Given this list of marker genes PDGFRB, FLT4, NSD1, ARHGAP26, TLX3, LIFR, NPM1, ACSL6, APC, RANBP17, here is a description of the gene set: DNA copy number amplifications activate oncogenes and are hallmarks of nearly all advanced tumors. Amplified genes represent attractive targets for therapy, diagnostics and prognostics. To investigate DNA amplifications in different neoplasms, we performed a bibliomics survey using 838 published chromosomal comparative genomic hybridization studies and collected amplification data at chromosome band resolution from more than 4500 cases. Amplification profiles were determined for 73 distinct neoplasms. Neoplasms were clustered according to the amplification profiles, and frequently amplified chromosomal loci (amplification hot spots) were identified using computational modeling. To investigate the site specificity and mechanisms of gene amplifications, colocalization of amplification hot spots, cancer genes, fragile sites, virus integration sites and gene size cohorts were tested in a statistical framework. Amplification-based clustering demonstrated that cancers with similar etiology, cell-of-origin or topographical location have a tendency to obtain convergent amplification profiles. The identified amplification hot spots were colocalized with the known fragile sites, cancer genes and virus integration sites, but global statistical significance could not be ascertained. Large genes were significantly overrepresented on the fragile sites and the reported amplification hot spots. These findings indicate that amplifications are selected in the cancer tissue environment according to the qualitative traits and localization of cancer genes. from publication Myllykangas S, Himberg J, Böhling T, Nagy B, Hollmén J, Knuutila S (PMID 16751803) species: Homo sapiens Human Gene Set: MYLLYKANGAS_AMPLIFICATION_HOT_SPOT_27 Amplification hot spot 27: colocalized fragile sites and cancer genes in the 5p15.3-p15.1; 5p12-q35 region.